Given this list of marker genes Cers1, Cers6, Cers4, Cers3, Tlcd3b, Cers5, Cers2, here is a description of the gene set: Mouse Gene Set: GOMF_SPHINGOSINE_N_ACYLTRANSFERASE_ACTIVITY studied in species Mus musculus Catalysis of the reaction: acyl-CoA + sphingosine = CoA + N-acylsphingosine.